The following is a description of a gene set: Any process that increases the rate, frequency, or extent of the controlled release of molecules that form the extracellular matrix, including carbohydrates and glycoproteins by a cell or a group of cells. Mouse Gene Set: GOBP_POSITIVE_REGULATION_OF_EXTRACELLULAR_MATRIX_CONSTITUENT_SECRETION species: Mus musculus, and this is the list of marker genes: Ier3ip1, Agt, Bmp2, Rgcc, Cpb2